Given this list of marker genes UBE2I, UBR5, UBE2K, UBE2G1, UBE2V1, UBE2V2, UBE2N, CYB561D2, UBE2D3 (ubiquitin conjugating enzyme E2 D3), UBE4A, UBE2A, UBE2B, UBL4A, UBE2D2 (NCBI Gene Id 7322), UBE2M, UBE2H, UBE2S, SUMO1, UBE2E1, UBE2D1, UBE2L6, here is a description of the gene set: species: Homo sapiens Human Gene Set: MODULE_4 Genes in the cancer module 4.